The following is a description of a gene set: Any process in which striated muscle adapts, with consequent modifications to structural and/or functional phenotypes, in response to a stimulus. Stimuli include contractile activity, loading conditions, substrate supply, and environmental factors. These adaptive events occur in both muscle fibers and associated structures (motoneurons and capillaries), and they involve alterations in regulatory mechanisms, contractile properties and metabolic capacities. species: Mus musculus Mouse Gene Set: GOBP_STRIATED_MUSCLE_ADAPTATION, and this is the list of marker genes: Myoz2, Lmna, Kdm4a, Bmp10, Pparg, Camta2, Myog, Mymk, Gtf2ird1, Atp2a2, Nfatc1, Nfatc3, Smad4, Atp2b4, Klf15, Gtf2ird2, Cflar, Nppb, Tnnc1, Myoz1, Chaer1, Actn3, Ezh2, Gata6, Mef2c, Errfi1, Nppa, Oga, Myoc, Mtor, Tnnt1, Smad1, Asb2, Myh7, Acta1, Cmya5, Myh6, Smad3, Inpp5f, Bmp2, Igfbp5, Bmp4, Gata4, Mlip, Ar, Tnni1, Ppp3ca, Tcap, Rps6kb1, Mir208b, Myod1, Acacb, Tead1, Gsn, Hey2, Mstn, Trpc3, Foxo1, Cacna1s